Given this list of marker genes Asb15, Rb1cc1, Tlr9, Hmgb1, Map3k1, Dusp19, Rassf2, Ccdc88c, Naip5, Rnf13, Tnik, Ltbr, Mbip, Traf4, Ankrd6, Fgd4 (FYVE, RhoGEF and PH domain containing 4), Wnt7b, Myd88, Plcb1, F2rl1, Crk, Ripk2, Gadd45a, Taok2, Rasgrp1, Trpv4, Edn1, Dvl3, Wnt16, Map3k7, Map4k4, Il1b, Card9, Mapk8ip1, Nrk, Ccl21d, Mink1, Tlr3, Tirap, Naip6, Myoc, Ager, Taok1, Naip2, Fgf15, Gadd45b, Tpd52l1, Unc5cl, Fzd10, Dvl2, Sh3rf3, Xiap, Tnfsf11, Il3, Nod2, Ccn2, Ptk2b, Ccl19, Mturn, Pja2, Dixdc1, Dkk1 (dickkopf WNT signaling pathway inhibitor 1), Ccl19-ps5, Hipk2, Pycard, Birc7, Nox1, Map3k10, Lmnb1, Ccl21f, Map2k7, Asb3, Tnfrsf19, Map4k2, Ccl19-ps6, Naip1, Tlr4, Wnt5a, Hras, Axin1, Dab2ip, Ccl21e, Dusp22, Ripk1, App, Ccl21b, Ccl19-ps1, Stk3 (NCBI Gene Id 80435), Gadd45g, Serpinf2, Sh3rf1, Map3k5 (NCBI Gene Id 320994), Zfp622, Fcgr2b, Edar, Cd27, Ccl19-ps3, Tnf (tumor necrosis factor), Il1a, Map2k4, Dab2, Wnt7a, Nod1, Cracr2a, Ccl19-ps4, Ccl21a, Eda2r, Mapkbp1, Mapk8ip3, Map3k11, Cdc42, Sh3rf2, Mfhas1, Slamf1, Flt4, Taok3, here is a description of the gene set: Mouse Gene Set: GOBP_POSITIVE_REGULATION_OF_JNK_CASCADE species: Mus musculus Any process that activates or increases the frequency, rate or extent of signal transduction mediated by the JNK cascade.